Given this list of marker genes Cd46, Cr1l, C4bp, Cr2, Susd4, Zp3r, here is a description of the gene set: Any process that stops, prevents, or reduces the frequency, rate or extent of complement activation by the classical pathway. Mouse Gene Set: GOBP_NEGATIVE_REGULATION_OF_COMPLEMENT_ACTIVATION_CLASSICAL_PATHWAY species: Mus musculus